Given this list of marker genes SPN, ALDH4A1, TRIM28, NIT2, HS2ST1, EZH1, OGG1, MAP3K7, AQR, CD46, HYCC2, TYW1, ITGA7, CRYBG1, SKIC3, CTCF, DNAJB5, ANXA11, RAVER1, R3HCC1, SNX29, CCR6, GCSH, ARHGEF12, EXD2, CCPG1, RPP14, PSMD5, FBXW8, IPO8, VPS50, FAM234A, SEC16A, GZF1, SMC5, KIFAP3, INSL6, FAM98B, KIF5B, ABCA3, PRKX, CDK9, THOC3, TRMT61A (NCBI Gene Id 414769), OCRL, CSTF1, NR1H2, RABEPK, FLG2, YJU2, CNKSR3, TXNDC9, SPG21 (NCBI Gene Id 51324), PPP6R1, ZHX1, HYOU1, NMB, TXNDC16, FUCA2, CHCHD5, ATG9A, FIG4, ANGPTL2, GTF2H2 (NCBI Gene Id 2966), ZDHHC8, SIDT1, ZFP30 (ZFP30 zinc finger protein), HABP4, JADE1, ZKSCAN1, ASH2L, SQOR, PRDM5, MOCS3, PMAIP1, TTC5, DDX41, MLH3, CWC27 (NCBI Gene Id 10283), HNRNPL, ADAMTS14, RDM1, PPP6R2, KLHL3, ACAA2, DHPS, PFKP, KIF16B, LPIN2, USP9X, ITPKC, GRWD1, ANXA1, METTL27, PROS1, GYS1, KLHDC2, KDM3B, XKR9, PDLIM4, TUBGCP2, WDR91, LRP6, PDCD1, PHACTR2, ORC3, AHI1 (Abelson helper integration site 1), MCOLN3, SEPTIN10, MED25, RWDD3, CSNK1E, EMB, NAT1, GPRC5B, PRKCZ, HSDL2, SEC14L1 (SEC14 like lipid binding 1), CCDC125, INPP4A, IKBKG, RSPRY1, MYO1D, DNAJB7, TRPT1, STAU2, RAPGEF2, MYO10, KAT5, OXNAD1, RAB3IP, CMAHP (cytidine monophospho-N-acetylneuraminic acid hydroxylase, pseudogene), VPS8, HELB, OPRPN, NR1D2, PLXNA1, NUP107, ECPAS, CAP2, CATSPERD, MGST2, XYLT2 (NCBI Gene Id 64132), SIPA1L1, UBR5, GOLPH3L, FBXW10, HSF2 (NCBI Gene Id 3298), NOMO1, ANGPTL1, ZAN, MTHFD2, TMEM209, FXR2, RAB3GAP2, TTLL1, CIBAR1, SKA2, MCM4, ZRANB1, RAB7A, CEP164, LSG1, DOCK9, PANK1, here is a description of the gene set: Human Gene Set: GSE10147_IL3_VS_IL3_AND_CPG_STIM_PDC_DN We used microarrays to detail the global program of gene expression underlying the effect of p17 on human plasmacytoid dendritic cells and was compared to CpG profile. studied in species Homo sapiens from publication Fiorentini S, Riboldi E, Facchetti F, Avolio M, Fabbri M, Tosti G, Becker PD, Guzman CA, Sozzani S, Caruso A (PMID 18310327) Genes down-regulated in plasmacytoid dendritic cells: IL3 versus IL3 and CpG.